Given this list of marker genes PIK3R1, JAK3, INPPL1, SOS2, STAT1, STAT4, IL3, HAVCR2, PIK3CB (NCBI Gene Id 5291), PTPN6, PIK3R3, CSF2, IL5RA, IL2RA, JAK2, IL15RA, PIK3CD, IL21, LGALS9, IL9, STAT3, IL21R, IL9R (interleukin 9 receptor), GRB2, PIK3CA, INPP5D, LCK, STAT5B, JAK1, IL3RA, STAT5A, SHC1, SYK, PIK3R2, IL15, CSF2RA, IL2, CSF2RB, IL2RG, IL5, PTK2B, IL2RB, SOS1, GAB2, here is a description of the gene set: Human Gene Set: REACTOME_INTERLEUKIN_2_FAMILY_SIGNALING Interleukin-2 family signaling studied in species Homo sapiens